The following is a description of a gene set: species: Homo sapiens Human Gene Set: GOBP_INTERLEUKIN_5_MEDIATED_SIGNALING_PATHWAY The series of molecular signals initiated by interleukin-5 binding to its receptor on the surface of a cell, and ending with the regulation of a downstream cellular process, e.g. transcription., and this is the list of marker genes: IL5, IL5RA, JAK2, LYN, STAT5A (NCBI Gene Id 6776), CSF2RB